The following is a description of a gene set: Animals cannot synthesize pyridoxal 5'-phosphate (PLP) which is a ligand in aminotransferases and other enzymes. PLP's accessible derivatives pyridoxine, pyridoxal, and pyridoxamine are traditionally called vitamins B6. They are taken up nutritionally from bacteria and plants, but also created from PLP in the body. The pathways used to recycle PLP from these three compounds can therefore be called vitamin B6 activation as well as PLP salvage. Because of the close similarity of the molecules, only two enzymes are needed for the task (McCormick & Chen, 1999). studied in species Homo sapiens part of: Metabolism of water-soluble vitamins and cofactors Reactome Pathway: Vitamin B6 activation to pyridoxal phosphate, and this is the list of marker genes: PNPO, AOX1, PDXK